The following is a description of a gene set: species: Homo sapiens Any process that modulates the frequency, rate or extent of natural killer T cell proliferation. Human Gene Set: GOBP_REGULATION_OF_NK_T_CELL_PROLIFERATION, and this is the list of marker genes: JAK2, ZBTB7B, IL23A, TYK2, IL18, RASAL3, IL12B